The following is a description of a gene set: Abnormal drinking behavior Human Gene Set: HP_ABNORMAL_DRINKING_BEHAVIOR Abnormal consumption of fluids with excessive or insufficient consumption of fluid or any other abnormal pattern of fluid consumption. studied in species Homo sapiens, and this is the list of marker genes: NLRP3, HPSE2, KCNJ5, IRF4, ARNT2, INSR, CLDN16 (claudin 16), HNF1A, CASR, OTX2, TMEM67, NPHP3, SLC41A1, DZIP1L, AVPR2, PKHD1, CISD2, ITPR3, BSND, NPHP4, PAX4, CACNA1D, DCDC2, HSD11B2, SOX3, HNF1B (NCBI Gene Id 6928), CLDN10, BBS2, CDC73, CYP11B2, KL, LZTFL1, PTPN22, NPHP1, KCNJ10, CYP11B1, KCNJ1, AVP, CTNS, TRANK1, WFS1, SLC5A2, NEK8, HESX1, FGFR1, IL6, PROKR2, NKX2-1, LRIG2, SLC12A3, AQP2, CLCNKB, BBS9, SOX2